Given this list of marker genes PRKCG, PLCG1, MAP2K1, MAP2K2, EGF, BRAF, PRKCA, PLCG2, RAF1, PRKCB, MAPK1, ARAF, EGFR, CCND1, MAPK3, here is a description of the gene set: Human Gene Set: KEGG_MEDICUS_REFERENCE_EGF_EGFR_PLCG_ERK_SIGNALING_PATHWAY species: Homo sapiens EGF-EGFR-PLCG-ERK signaling pathway. Pathway ID: N00023. Pathway type: Reference. Pathway class: nt06266 Non-small cell lung cancer. Pathway Definition from KEGG: EGF -> EGFR -> PLCG -> IP3 -> (Ca2+,DAG) -> PKC -> RAF -> MEK -> ERK -> CCND1